Given this list of marker genes Igfals, H1f1, App, Smoc1, Ccn5, Vtn, Furin, Mmp7, Fstl1, Rtn4r, Prss34, Cxcl10, Chrd, Sfrp1, Itgam, Ccn3, Ccn4, Hrg, Ang2, Vegfb, Tnxb, Fbn1, Hmgb1, Comp, Rspo3, Aplp2, Clec3b, Adamts1, Efemp2, Ccn1 (NCBI Gene Id 99596), Apoa5, Col25a1, Serpine2, Slit2, Ang6, Bsph2, Nrp2, Rspo4, Col5a3, Hsd17b12, Pdcd5-ps, F11, Vegfa, Bmp4, Ccdc80, Hdgf, Angptl3, Lrpap1, Lpl, Eva1c, 2300002M23Rik, Postn, Lxn, Apoe (apolipoprotein E), Pcolce, Apob, Ltbp2, Smoc2, Rspo2, Ltf, Prelp, Ncam1, Ptprc, Abi3bp (ABI family member 3 binding protein), Thbs2, Fgfr1, Saa1, Ptprf, Tgfbr3, Ang, Ccn2, Selp, Col23a1, Lipi, Gpnmb, Twsg1, Fgf1, Ctsg, Fn1, Aoc1l2, Adgrg1, Apoh, Col11a1, Lipc, Bsph1, Cfhr2, Serpinc1, Nrp1, Ecm2, F2, Reg4, Aoc1l3, Fgfr4, Fgfrl1, Aplp1, Cfhr4, Rspo1, Fgf9, Grem2, Mdk, Ccl5, Adamtsl5, Fgf12, Lgr4, Aoc1l1, Mstn, Cxcl11, Cma2, Crispld2, Defb34, Bmp7, Ccl2, Fgfr2, Cfh, Col5a1, Slit3, Pla2g5, Fbln7, Tpsb2, Liph, Pcolce2, Pdcd5, Colq, Slit1, Ptch1, Adamts8, Ang4, Adamts5, Ccn6, Hbegf, Fgfbp3, Lamc2, Ptn, Ang5, Pla2g2d, Rtn4rl1, Nav2, Cxcl13, Fgf10, Tmem184a, Prss57, Ndnf, Aoc1, Pf4 (NCBI Gene Id 56744), Serpind1, Zfp207, Impg1, Thbs4, Mpo, Thbs3, Nell1, Fgf14, Defb15, Elane, Adamts15, Nell2, Fgf7, Pcsk6, Col28a1 (collagen, type XXVIII, alpha 1), Thbs1, Lipg (NCBI Gene Id 73116), Mcpt9, Serpina10, Sost, Ccl8, Ccl7, Alk, Col13a1, Fgf2, Rpl29, Rpl22, Impg2, Ptprs, here is a description of the gene set: Mouse Gene Set: GOMF_HEPARIN_BINDING Binding to heparin, a member of a group of glycosaminoglycans found mainly as an intracellular component of mast cells and which consist predominantly of alternating alpha-(1->4)-linked D-galactose and N-acetyl-D-glucosamine-6-sulfate residues. studied in species Mus musculus